Given this list of marker genes IGF2BP3 (insulin like growth factor 2 mRNA binding protein 3), VDAC1, PAK5 (p21 (RAC1) activated kinase 5), PRKCG, MCL1, GNAI1, RAB14, ADAM28, LZTS3, FAM91A1, AGPS, NEGR1, IDE, MEX3B, ARFIP1, BHLHE41 (NCBI Gene Id 79365), QSOX2, SMAP1, DCBLD2, DCP1A, CFLAR, ATP11A, DUSP16, CDKL5, SNTB1, FIGN, BNC1, DMXL1, SERF1B, TMEM64, NRXN1, NRN1, PBX1, CPD, RAD21, GCG, SDHD, USP25, CYLD, ATG14, ITPK1 (inositol-tetrakisphosphate 1-kinase), LMO3, EIF2D, RASA1, GXYLT1, TENT4B, PELI2, DHDDS, ACBD3, CD274, SOAT1, ELL2, BLCAP, TFCP2L1, EYA1, EOGT, ABCC5, RNF185, PCDHA11, ARHGAP5, BRWD3, PDZD8, SHCBP1, RBM24, LARS1, YOD1, FOXQ1, IPO7, PALLD, HADH, ZKSCAN4, KLF13, PCDHA2, MDGA2, PDE1C, USP46, MAPK8IP3, NPAS2, PPM1B, PHF1, FHIP2A, ITGB1, LRP6, RELL1, AFF4, SLC25A36, JPT2, MTCL2, ZNF670, ONECUT2, TUSC3, DLX1, FLRT3, CREB5, ACTL6A, GSPT1, MLLT3, CDK6, KLHL36, DNER, SAV1, ACOT7, PHC3, PCDHA7, BAZ1A, NALF1, ALOX12, KCNS3, CDK13, WDR19, CEMIP2, TRIM32, SPPL2B, JMY, CNOT6, ERMN, ADIPOR1, PTGFRN, NETO1, PCDH19, HECTD2, SATB2, RBMS3, PPP1R3E, PCDHA3, ADCY3, ARPP19, MLF1, SEC63, TGOLN2, PAN3, SOBP, CXCL14, NABP1, TBC1D15, RBBP6, ARF1, LRRTM1, EMILIN2, TMEM47, RBFOX2, COPS2, SGCB, UBR3, CUX1, ATL3, ANKRD13A, ZSWIM6, ITSN2, GPCPD1, BLOC1S5, PALM2AKAP2, MAGI1, FAM117B, CALN1, PCMTD1, SEMA3A, APPL1, NRP1, TSC1, CNOT7, RIOK3, GABPB2 (GA binding protein transcription factor subunit beta 2), BOD1L1, DCC, FRRS1L, BMPR1A, ESRRG, EFS, GSPT2, ZDHHC3, CNTNAP5, PFKM, TDP1, PCDHA9, TRABD2B, ZNG1E, PRPS1, PCDHA12, CNOT6L, TMEM108, PCDHAC2, HSPA4, PCDHA4, ABHD13, RIT1, RNF138, DYNC2H1, GTPBP2, NAP1L5, HYCC2, GRIK1, UMAD1, GABRP, ZC3H7B, STK26, TFAP2B, CERT1, COMMD3-BMI1, ZBTB44, YWHAH, CPEB3, SESN3, PHC1, PCDHAC1, PCDHA6, N4BP1, UTP14C, GNPDA2, ENY2, PLEKHA5, RAB18, SPOPL, KITLG, GPBP1, CD74 (CD74 molecule), SMARCD2, CDH20 (cadherin 20), RBPJ, TC2N, ARMCX2, RAI2, EXO1, AGFG1, KLHL15, BNIP3, HIVEP2, NXT2, AK4, PCDHA13, NR2C2, PCGF5, IRF6, SH2B3, PBX3, ELOVL6, PCDHA5, ZNF652, WWC2, CD96 (NCBI Gene Id 337949), CXXC4, DTNA, TIGAR, SLC9A2, HIPK3, ETV1, VHL, NUFIP2, MXI1, ATF7IP2, TSHZ3, C6orf118, DDX54, HSPH1, VEPH1, PCDHA1, CNKSR2, TRIAP1, MFSD14A, MAPK9, TBX4, PIGK, CPED1, MTDH, ZNF281, GTF2A1, NCK1, CDH2, IPO5, RP2, MANBA, KLF5, DSCC1, RCN2 (NCBI Gene Id 5955), TNPO1, LHFPL3, FEM1B, SH3GL1, CYP1A2, NAA20, PIK3CA, CAPRIN1, PLXNC1, RHOBTB1, DISC1, SAXO1, RC3H1, GSKIP, ENTPD4, HELZ, CANX, IDS, TMEM255A, PCDHA8, MTRF1, GOPC, PDK1, GPRASP1, GNS, RBMXL1, MPPED2, PCDHA10, ING5, MAPDA, MINDY2, SMNDC1, CYTH1, SERF1A, ARL8B, PLPPR1, here is a description of the gene set: Genes predicted to be targets of miRBase v22 microRNA hsa-miR-320a-3p, hsa-miR-320b, hsa-miR-320c, hsa-miR-320d in miRDB v6.0 with MirTarget v4 prediction scores > 80 (high confidence targets). species: Homo sapiens from publication Chen Y, Wang X (PMID 31504780) Human Gene Set: MIR320A_3P_MIR320B_MIR320C_MIR320D